Given this list of marker genes Prkar1a, Prkacb, Pde4c, Pde4a, Ppp1r1b, Pde4d, Prkaca, Prkar1b, Ppp1ca, Ppp2ca, Ppp2cb, Pde4b, Ppp2r1a, Ppp2r1b, Ppp2r5d, Cdk5, here is a description of the gene set: Mouse Gene Set: REACTOME_DARPP_32_EVENTS DARPP-32 events studied in species Mus musculus